Given this list of marker genes Mapre3, Sfn, Spdya, Tfap4, Ccnd2, Spdye4a, Ccny, Psmd10, Pim1, Ccnd3 (cyclin D3), Blm, Stil, Cdkn2a, Hhex, Plk1, Cdk5rap1, Tnfaip3, Men1, Casp3, Ccnd1, Cdkn2b, Rgcc, Lats1, Hexim2, Inca1, Akt1, Prox1, Cdk5rap3, Cdkn2c, Lats2, Pten, Adam17, Cdkn2d, Wee2, Fbxo7, Gtpbp4, Cdkn1a, Apc, Psrc1, Myocd, Cdkn1b, Nr2f2, Bccip, Kat2b (NCBI Gene Id 320956), Egfr, here is a description of the gene set: studied in species Mus musculus Any process that modulates the frequency, rate or extent of cyclin-dependent protein serine/threonine kinase activity. Mouse Gene Set: GOBP_REGULATION_OF_CYCLIN_DEPENDENT_PROTEIN_SERINE_THREONINE_KINASE_ACTIVITY